Given this list of marker genes GLB1, MAN2B2, CTSB, GALNS (galactosamine (N-acetyl)-6-sulfatase), ARSB, PPT1, HYAL1, NAGLU, GPC3, CTSK, LIPA, SERPINB13, SCARB2, GC, KERA, ARSA, TXNDC5, SPACA7, IDS, OMD, FMOD, GPC4, MAN2B1, CTSS, CTSF, PLD3, HSPA8, FASLG, DCN, PDGFRB, NSG1, TCN2, AGRN, CTSL, HPSE, CUBN, PLBD2, HSP90AA1, GBA1, PSAP, RNASET2, NEU1, SMPD1, GLA, CHID1, CD1E, GM2A, GNS, PRELP, CSPG4, CBLIF, SDC1, CTSA, VCAN, LUM, ACP2, IFI30, PPT2, NSG2, GPC6, ACAN, CTSD, HGSNAT, APOB, SDC2, SGSH, SDC4, BGN, CD74, HEXB, OGN, NEU4, GPC5, NAAA, GALC, HEXA, ASAH1, CSF3, ATP13A2, NCAN, GPC1, HSPG2, BCAN, CSPG5, EPDR1, TPP1, IDUA, SDC3 (NCBI Gene Id 9672), GUSB, GYG1, MANBA, CTSV, GAA, LGMN, FUCA1, LAMP2, NPC2, GPC2, here is a description of the gene set: Human Gene Set: GOCC_LYSOSOMAL_LUMEN species: Homo sapiens The volume enclosed within the lysosomal membrane.